Given this list of marker genes NCF1, AR, NCOA4, RWDD1, SLC39A9, SIRT1, SPP1, MSN, ELK1, SRD5A1, ROCK2, here is a description of the gene set: studied in species Homo sapiens Any process that results in a change in state or activity of a cell (in terms of movement, secretion, enzyme production, gene expression, etc.) as a result of a testosterone stimulus. Human Gene Set: GOBP_CELLULAR_RESPONSE_TO_TESTOSTERONE_STIMULUS